The following is a description of a gene set: Abnormal T cell subset distribution Human Gene Set: HP_ABNORMAL_T_CELL_SUBSET_DISTRIBUTION Abnormal increase or decrease of any T cell subpopulation, measured as percentage of total CD3+ T cells in the blood, compared to a reference range for a given sex and age-group. species: Homo sapiens, and this is the list of marker genes: DIAPH1, GATA2 (NCBI Gene Id 84724), IKBKB, PGM3, CD3G, PSMB10, LCK, POLD1, WIPF1, LAT, RAG1, PIK3CG, ATP6AP2, WDR1, KMT2D, IL2RG, RASGRP1, PSMB9, CARD9, BLM, IRF1, BCL11B, FAS, OTULIN, RHOH, FASLG, CTPS1, PIK3CD, TNFRSF1B, LIG1, UNC119, DEF6, CASP8, CTLA4, CASP10, POLD3, SASH3, IL2RB, CTNNBL1, SYK, ZAP70, CD8A, DCLRE1C, KDM6A, MAP3K14, RAG2, IVNS1ABP, SEC61A1, EXTL3, MYC, LEP, FOXP3, CIITA, PIK3R1, WAS, ATM, CD3D, PNP, LEPR, TCF3, LCP2, FOXN1, NSMCE3 (NSE3 homolog, SMC5-SMC6 complex component), TOM1, BCL10, IL7R, CARD11, CD28, RFXANK, MAGT1, CD4, IL2RA, CD3E, SMARCAL1, EPG5, POMP, DOCK8, NCKAP1L, AP3B1, RFXAP, ITK, CD247, HLA-DPB1, RFX5, KNSTRN, RNF31